The following is a description of a gene set: The regulation of blood pressure mediated by detection of stimuli and a neurological response. Mouse Gene Set: GOBP_NERVOUS_SYSTEM_PROCESS_INVOLVED_IN_REGULATION_OF_SYSTEMIC_ARTERIAL_BLOOD_PRESSURE studied in species Mus musculus, and this is the list of marker genes: Adra1a, Klk1b26, Ace2, Drd2, P2rx2, Agtr1b, Rps6ka2, Tnni3, Chrm3, Mecp2, Tacr1, Agtr1a, Nav2, Manf, Adra1b, Adra1d, Chrna7, Asic2, Agt, Kcnk3, Agtr2, Sod2, Calca